The following is a description of a gene set: Genes up-regulated in immature neuron cell line: control versus interferon alpha (12h). Human Gene Set: GSE16450_CTRL_VS_IFNA_12H_STIM_IMMATURE_NEURON_CELL_LINE_UP Human neuronal differentiation alters responsiveness to innate immune stimuli and virus infections. We used microarrays to examine the transcriptional responses of the human BE(2)-C neuroblastoma cell line to retinoic acid-induced differentiation and type I IFN stimulation. from publication Peltier DC, Simms A, Farmer JR, Miller DJ (PMID 20483728) studied in species Homo sapiens, and this is the list of marker genes: GSAP, TANC2, PUDP, TBC1D5, TNIK, SNHG11, PATL2, XIST, PDCD4-AS1, ADNP2, CREB3L2, FOCAD, MBTPS2, GSK3B, GPHN, KDM4A, MSTO1, PRKCA, PSMD5, TSEN2, PDIA5, USP51, SOCS3, MAML2, LRBA, CCT6B, BIVM, ITGA6, RADX, DOCK2, ELAC1, NBAS, FBXO4, SKAP1, MPRIP, TECPR1, TSPYL5, FARSB, BABAM2, CMSS1, OXCT1, TANGO6, METTL2B, METAP1D, SND1 (staphylococcal nuclease and tudor domain containing 1), FUS, SCFD2, ABTB3, QSOX2, EXOSC2, PMS2P1, RNGTT, ATF7IP2, UCP2, RALGAPA2, ADGRA3, PLD6, MDN1, IVD, SPINT2, CARMIL1, PEX7, GABPB1-IT1, WWOX, CDIN1, SMIM8, DTD1, PCSK5, FUT8, ZMYND8, TMEM135, HSD17B8, PEX10, DPYD, ST20-AS1, PPP1R10, SLC39A11, PPP2R1B, UBL3, SKAP2 (src kinase associated phosphoprotein 2), DDX19B, GMDS, RTN4IP1, ITFG2, PARN, CLASP2, SLC7A1, MIEF1, WWP2, OTUD4, EHBP1, ACACA, TAF3 (NCBI Gene Id 83860), MED13L, RABL3, UBIAD1, PCNT, NBEA, DLG1, GFM1, MLXIP, CTPS2, PRPF38B, TPK1 (NCBI Gene Id 27010), ITFG1, NF1, RASGRF2, BLM (NCBI Gene Id 641), PPP2R2B, MRTFB, DHX33, PCCA, ABL2, OSBPL1A, KLF12 (NCBI Gene Id 82238), PBX3, PDSS2, XPR1, THOC1, VWA8, POLA1, EXT1, ZBTB40, ZBTB20, NDC1, UTRN, NAGA, MIPEP, RHNO1, SPIN3, USP7, NSMCE1, URB2, LDAH, ASXL1, FARS2, ARHGAP15, GNAQ, HNRNPH3, GTPBP4, ATXN7L1, VPS13D, AGPS, STAU2, HNRNPA3, HECTD4, TASP1 (NCBI Gene Id 55617), MSRA, FBXL17, SLC9A8, FBXW7, SLC9A9, GPD1L, UVRAG, THADA, PRKCB, SAMHD1 (SAM and HD domain containing deoxynucleoside triphosphate triphosphohydrolase 1), C10orf143, ZNF407, GPATCH2, TNRC6A, DENND6A, DIAPH2, DNAJC27, BBS9, CIRBP, ARB2A, UBASH3B, FUCA2, ANXA2R-AS1, STX8, PRKCQ, LINC00667, ZNF839, CASK, POLR3A, POLR3B, VPS13B, NUDT7, BTRC, DDX10, SMYD3, DNAJC30, ATP10A, PRKAG2 (NCBI Gene Id 7981), FCHSD2, SLC20A1, ADK, RSRC1, GMEB1, ZNF689, SLC35B4, SLC16A6, DGLUCY, HERC2, LPP, TRERF1